The following is a description of a gene set: Human Gene Set: REACTOME_INTERLEUKIN_RECEPTOR_SHC_SIGNALING Interleukin receptor SHC signaling studied in species Homo sapiens, and this is the list of marker genes: CSF2RA, IL3RA, IL5, SHC1, IL2RB, SOS1, JAK1, IL2RA, PIK3R2, PIK3CD, PIK3R3, CSF2, IL5RA, JAK2, IL2, INPP5D, IL3, PIK3R1 (NCBI Gene Id 5295), GRB2, GAB2, IL2RG, JAK3, INPPL1, CSF2RB, PIK3CB, PIK3CA, PTPN6